Given this list of marker genes ATN1, PHGDH, LIFR, NR2F2, DNAAF2, CCNO, POLR1C, CDC42, SMARCC2, TGFB3, SPEN, POGZ, BUB3, FOXC2, NAA10, ACVR2B, TGDS, LUZP1, ERMARD, APOE, NAE1 (NEDD8 activating enzyme E1 subunit 1), CTU2, KDM5A, FLI1, CIROP, KAT8, PALB2, RASA2 (RAS p21 protein activator 2), TSC1, THSD4, DHCR7, SLX4, SMOC1, COL1A2, TGFBR2, NIPA2, COL5A1, STK36, LTBP1, GLYCTK, LIMK1, ERCC8, ZMYM2, NCAPG2, EZH2, ODAD2, WDR26, SMARCD1, CHST3, MYPN, RRAS2, OTUD5, NEK9, CDK8, HCCS, IFT140, ALB, ALG3, STAG2, IFT27, TBX4, TBX20 (NCBI Gene Id 57057), PLD1, FIG4, KCNT1, PIGT, FMR1, TSC2 (TSC complex subunit 2), PCNT, SIX3, GTF2IRD2, HSPG2, SMARCA4 (NCBI Gene Id 6597), CD96, RAD21, ARID1B, OSGEP, IGF2, HEATR3, PAK2, PPP2R1A, ADH5, SON, ZMIZ1, CFC1, CACNA1C, THSD1, PTEN, RPL31, BCR, ECE1, BMPR2, FANCL, GJA5, TNFSF11, ACSL4, DNAAF6, KDR, ARX, DPH5, RBM10, KCNE5, WRN, ADAT3, NEK8, WT1 (WT1 transcription factor), TRIP13 (thyroid hormone receptor interactor 13), HGD, TPM2 (tropomyosin 2), SMC3, HTRA2, PUF60, SMC1A, CWC27, ESS2, FOXE3, MEG3, HDAC4, HIRA, AFF4, QRICH1, MYRF, MED25, PTH1R, ANGPTL6, CXCR2, BRCA1, FLT4, ABCD4, GATA4, CTCF, FKBP14, MEIS2, EOGT, ERCC4, ALX3, SKI, RFC2, ALDH18A1, TCIRG1, CHUK, IFIH1, RNASEH2A, RPS20, RPGR, ADK, RAB23, GTF2I, PTPN11, CASZ1 (NCBI Gene Id 654487), IPO8, ENPP1, NSD1, B3GALT6, ABL1, MAF, TCOF1, FOXH1, KANSL1, MYLK, VPS37D, PEX1, IL12B, ENG, ALG8, DLL3, RPS19, ABCC9, SALL1, KAT6B, PPFIBP1, SOX4, LRRC56, CHRM3, TGFBR1, PLXND1 (plexin D1), KYNU, ADAR, BMP2, LMX1B, ADA2, MMP2 (NCBI Gene Id 4313), WBP4, FTO, MCIDAS, NIPA1, MYH11, FBN1, ABCG5, SLC2A10 (NCBI Gene Id 81031), RBP4, CADM3, ZMYND10, RPS17 (NCBI Gene Id 6218), CDH2, MKKS, TALDO1, NOD2, MLXIPL, CCDC22, PRIM1, CXCR4, FLNA, SAMHD1, RNASEH2C, NOTCH1, TGFBR3, DOHH, HLA-DRB1, ARID1A, GAS1, TMCO1, DPM1, TBX2, MYCN, BUB1, ACTB, FGF10 (NCBI Gene Id 2255), DGCR6, RNASEH2B, UQCRFS1, TBC1D24, DTNA, STRA6, EMILIN1, EIF4A2, RBM8A, CCNQ, NAA20, RSPH9, AGGF1, BMPR1A, AGO2 (argonaute RISC catalytic component 2), ERCC6, NME8, RSPH3, ADAMTS17, FKTN, SMAD6, SLC29A3, FBXO11, DGCR2, RAI1, TWIST1, NEDD4L, MLX, RSPH4A, GBA1, RRAS, C12orf57, ODAD3, KCNJ8, FGFR2, GNPAT, GPC6 (NCBI Gene Id 10082), PIK3CA, RPL35, GLB1, FGFR1, FANCI, HIBCH (3-hydroxyisobutyryl-CoA hydrolase), PLCB1, CCDC40, RPS26, OFD1, WAC, COX7B, UMPS, TUBG1, CFAP74 (NCBI Gene Id 93196), TLL1, APOB, TAB2 (TGF-beta activated kinase 1 (MAP3K7) binding protein 2), DNAH5, THOC6, FGF8, CRKL, BGN, DISP1, TAOK1, DRC1, RPS28, DDX59, DNAAF5, INTU, KDM3B, TFAP2B, NPHP3, RREB1, NIPBL, EFEMP2, COL3A1, SOS2, PLCB3 (NCBI Gene Id 5331), NOTCH2, PORCN, MCTP2, TNNT2, CSGALNACT1, BUB1B, SALL4, ADAMTS19, RPL27, TRIP11, DNMT3A, MRAS, SCN2A, SLC35A2, LARS2, MED13L, POLR1D, MMP21, MYH7, GLI3, MAD2L2, B3GAT3, STIL, HRAS, SPEF2, TSFM, EXT2, PIGA, CLXN, HACD1, RAC1, GATA5, EBF3, AXIN1, GPC3, BRCA2, CLCN7, SLC34A2 (NCBI Gene Id 153010), NRAS, DNAJC30, EED, PKD1, CALM3 (NCBI Gene Id 808), COG6, WDR37, EIF2AK3, NKX2-6 (NK2 homeobox 6), USP18 (NCBI Gene Id 11274), IFNG, MAT2A, BRAF, CFAP298, TMTC3, COA6, SIK3, STXBP1, HEY2, RPL35A, MESP2, SOX11, PLCH1, LRPPRC (leucine rich pentatricopeptide repeat containing), NODAL, ABCG8, AMMECR1, GABRD, SCN1A, PRDM6, RPS27, WDR35, DLL4, DPF2, YY1, DDX3X, NAA60, NEK10, CRIPTO, ZFPM2, RPL5, STX1A, DNAAF1, PLOD1, ALDH1A2, B3GLCT, BICC1, ROR2, ROBO4, UFD1, ACTA2, OCLN, TBCK, SOS1, PKD1L1, SKIC2, SH3PXD2B, GLI2, BAZ1B, TBX1, NOTCH3, LDLR (low density lipoprotein receptor), PIK3R2, FBXL4, ESCO2, SNX14, RSPO2, HES7, ZMYM3, SMG9, ROBO1, RIPPLY2, SMC5, TREX1, LMNA (NCBI Gene Id 7816), TRAF7, BRIP1, FLNB, FOXF1, ITPR1, TGFB2, PIGL, APC2, COL18A1, NSMCE2, ZNF148, SOX2, SEMA3E, FUT8, DGCR8, MED12, ZNF699, SPTBN1, SPRED2, RTL1, ASCC1, BUD23 (BUD23 rRNA methyltransferase and ribosome maturation factor), VPS33A, SNX10, GJA1, RPS29, WASHC5 (WASH complex subunit 5), NDUFB11, YY1AP1, MAPK1, DACT1, SLC25A24, SPAG1, GDF1, VAC14 (VAC14 component of PIKFYVE complex), CEP295, DHCR24, MRPS16, ERF, KDM6A, UBR7, RNU7-1, FANCM, EHMT1, ARL6IP6, FKBP6, CCDC39, SRY, RPL18, CBL, THBS2, SKIC3, EIF2AK4, TGIF1, DNAH9, TMEM94, FANCC (NCBI Gene Id 2176), MAP1B, SF3B4 (NCBI Gene Id 171), ELN, RAP1B, PGM1, DVL3, CREBBP, DPYSL5 (NCBI Gene Id 56896), NXN, LTBP4, DNAJB11, RPL8, SMAD3, SHANK3, TRAIP, AEBP1, ODAD4, MYOCD, NADSYN1, G6PC3, RAB34, MKS1, PQBP1, IDS, RSPRY1, PPP1CB, TBL2, LTBP2, ARSL, SMG8, FOXJ1, CYP7A1, GAS2L2, UBE2T, RPS24, NF1, ARID2, PRDM16 (NCBI Gene Id 647868), RIT1, DYRK1A, COQ4, CCDC47, MFAP5, PRKCD, ATP6V1E1, PGM3, RNU4ATAC, MEGF8, NKAP, RIN2 (Ras and Rab interactor 2), USP9X, BCL11B, MAP2K1, SHH, RPL10, CFAP300, RPL15, TELO2, BRF1, ABCC6, ZFX, ZMPSTE24, RAF1, FOCAD, ALG12, FBN2, ANKS6, GTF2IRD1, LDLRAP1, LSM11, DDX11, RNU4-2, RPL9, COL5A2, CFAP221, GNA11, DNAI2, RFWD3, POLR1B, JAG1, KCNQ2, DNAAF4, DMPK, POLA1, BICRA, LZTR1, FANCG, DNAJB13, MYH3, EIF4H, NONO, PLAGL1, DNAH1, TRIO, MMP14, POLR1A, TP63, PSMD12, ZIC2, KRAS, RPS7, HNRNPK (NCBI Gene Id 3190), SLC25A22, PTPN22, FANCF, SMAD2, FOXC1 (forkhead box C1), BAP1, TKT, STX5, RPL26, GJA8, CEP120, PCGF2, ESAM, AASS, GPC4, SF3B2, PRKCZ, FANCD2, CHD4, VPS35L, SCAF4, SUCLG1, SNRPB, MASP1, SIX6, TRIP4, CARS1, PRKG1, DNAH11, ZNF462, ZIC3, HYDIN, DNAI1, HYMAI, FRA10AC1, IFT56, WNT4 (Wnt family member 4), ARF1, COL1A1, PIGN, CRTAP, EGFR, TSR2, SMARCA2, KMT2B (NCBI Gene Id 9757), SLC12A5, FANCA, ATP6V1A, HPGD, CFAP53, SUFU, UBE2A, NPR3, TBX5, BPTF, DYNC2LI1, PDPN, CITED2, SSR4, SFTPB, FOXP2, GNB2, TRRAP, DOCK6, RAD51C, METTL27, XRCC2, LYN, CRELD1, DLK1, KMT2A, CDC42BPB, KCNAB2 (potassium voltage-gated channel subfamily A regulatory beta subunit 2), AMER1, TPM3, BCOR, SAMD9, TTC12, ARVCF, ALX1, C2CD3, KAT6A, SLC37A4, SUPT16H, JMJD1C, UFC1, CPLANE1, RBPJ, GP1BB, LFNG, ATP2B1, TAF4, PTCH1, ATP6V1B2, SRCAP, PIGO, NCF1, MED11, CEP57, FANCB (NCBI Gene Id 2187), EP300, PRDM13, FADD, RAD51, WDPCP, RERE, GANAB, LOX, MGAT2, MGP, IFT43, PCSK9, NME5, GATA6, CNTN1, ALG9, FBLN5, DIS3L2, HLA-B, ODAD1, KMT2D, CHD7, UNC45B, NKX2-5, MMP23B, PKD2, MID1, ZEB2, RPS10, PEX19, MAP3K7, ANK1, DEPDC5, CHRNG, CLIP2, DLL1, SMARCB1, ARHGAP31, RSPH1, P4HA2, ARFGEF2 (NCBI Gene Id 10564), LMBRD1, DNAAF3, NFIX, SMARCE1, SNRPN (small nuclear ribonucleoprotein polypeptide N), ZBTB7A, KCNH1, RPL11, UBE3B, DAW1, RPS15A, SEC24C, TRPV6, DNAL1, PACS1, PAH, TMEM270, CDON, UBE4B, GATA1, ADAMTS10, COMT, FGFR3, ALG5, KCNN3, SPECC1L (NCBI Gene Id 8221), WLS, DNAAF11, CUX1, BRD4, SMAD4, MAPKAPK5, ASXL2, TMEM260, FANCE, PRKACB, IGBP1, here is a description of the gene set: species: Homo sapiens Human Gene Set: HP_ABNORMAL_MORPHOLOGY_OF_THE_GREAT_VESSELS A structural anomaly affecting a blood vessel involved in the circulation of the heart, i.e., the superior or inferior vena cava, the pulmonary arteries, the pulmonary veins, and the aorta. Abnormal morphology of the great vessels